The following is a description of a gene set: Mouse Gene Set: GOBP_REGULATION_OF_FC_RECEPTOR_MEDIATED_STIMULATORY_SIGNALING_PATHWAY species: Mus musculus Any process that modulates the rate, frequency or extent of the Fc receptor mediated stimulatory signaling pathway.., and this is the list of marker genes: Lyn, Appl1, Pten, Rapgef1, Rap1a, Plscr2, Cd47, Appl2, Csk, Rabgef1, Cd226, Plscr1, Ptprc, Ptprj